The following is a description of a gene set: Human Gene Set: GOBP_REGULATION_OF_MOLECULAR_FUNCTION Any process that modulates the frequency, rate or extent of a molecular function, an elemental biological activity occurring at the molecular level, such as catalysis or binding. studied in species Homo sapiens, and this is the list of marker genes: KCNE3, TSG101, GAPDH, VMA21, ETAA1, ERBIN, NT5DC2, PSAP, TMSB4X, RASGRP2, SNCA, TERT, GABARAPL2, PSME3IP1, BAG5 (BAG cochaperone 5), WNT5A, VMP1, CBARP, GOPC, STX4, MAP3K11, HEY2, DTX3L, BCAS3, HTT, MT3, WNK2, TLR9, IL20, OPRM1, NOD2, ZNF16, USP33, ARHGAP11A, RHEBL1, CALM3, TLR4, SUMO4, ZFP91, ATP13A2, GNAS, KIT, PHB2, SYNGR3, DFFA, VAV3, MIR138-1, RALB, PIK3R5, FXN, LRRC52, BMP2, PDGFRB, SIRT1 (sirtuin 1), SOCS4, TESC, FGR, BTRC, RPS6KA4, KLRC4-KLRK1, EDNRA, EDN1, NUPR1, WRN, CASS4, CRNN, SNF8, ANGPT1, HAND2, ITGB1BP1, RCC2, RWDD3, CHTF8, RAP1A, DBI, PIP5K1A, RAN, COPS5, SRC, POU4F2, MDFI, COX17 (NCBI Gene Id 10063), PLA2G5, CRHBP, TBC1D10B, RAB3GAP2, VAV1, A2ML1, UBE2C, RIPOR1, CCDC88A, TFDP1, DEFB114, ESR2, MRNIP, CREBZF, USP7 (NCBI Gene Id 7874), KCNAB1, KLRK1, RACK1, ADARB1, APC2 (NCBI Gene Id 10297), CARD11, DOCK11, TFAP4, TRIM8, PYHIN1, CD300A, ACP4, KIF14, RCN3, ODAM, LRRC14, ABCE1, SOX11, TRIB2, HERC5, BAMBI, TBC1D30, EVI5L, MMP9, CCNE2, CTSS, GTF2F1, ATP5IF1, ACTN4, DIPK2A, EIF2AK4, USP44, GPRC5B, FOXC1, CNIH3, STAC2, MITD1, CORO1C (coronin 1C), INS, TPX2, KCNE2, CAND1, DOCK9, TRPC6 (NCBI Gene Id 7225), CGA, UNC119, TLE5, ACR, RELA, OXA1L, CRTC2, AGAP2, SNX18, FLT3, ADAR, HCK, SERPINB13, BDNF, CDC20, LIMS1, TMED2, MMUT, SERPINB8, TGM2, CAMK1, STK38, PCNA, PPIF, BTK, NPR3, CCR2, RHOC, TRIM15, GIPR, CNIH2, FSHB, PARP9, MYL4, GMNN, SUMO3, IL10, CD40LG, RARA, RGN, CACNA1D, SCN1B, CACNG7, AGER (NCBI Gene Id 177), STRIT1, PTPN22, RSU1, TOR1AIP2 (torsin 1A interacting protein 2), NIBAN2, MAP4K2, TRIM38, SCRIB, CRIPTO, PPP1R12A, CCDC125, ARHGAP44, CEP43, CDKN1B, TRIM27, GNAI2, PTPRC, KCNE1, NHEJ1, DHX9, ADGRV1, CNRIP1, NGEF, ARFGEF1, RGS1, ILRUN, EEF1A2, TRAF2, CRACR2A, FEM1B, XRCC1, ADAM17, TRIB3, RB1, ARHGEF16 (NCBI Gene Id 27237), RGS10, UBE2N (ubiquitin conjugating enzyme E2 N), AGRN, ITGA6, FIRRM, SKP1, ADGRG3, NLRP2B, TNNT2, MED25, BAX, PATE4, CDK5RAP1, PRSS22, PRDX3 (peroxiredoxin 3), ADORA2B, GNAI3, DYNAP, TCAF2, FEM1A, GCH1, PRELID1 (PRELI domain containing 1), COMMD1, RAB3GAP1, MST1R, CRHR1, TPD52L1, CDC25C, UBXN1, MIR92B, ECT2, TBC1D15 (NCBI Gene Id 64786), NFKBIL1, CARD10, ADIPOQ, LARS1, RALBP1, PPARG, IL18RAP, GPLD1, SIRT2, CD4, TBC1D20, CDC14B (cell division cycle 14B), PRKCH (protein kinase C eta), USP6NL, MIR27B, IL26, ATF2, RGS14, PLXNB2, CDK5R1, EPHB3, MET, CHP1, RAPGEF6, TNFSF18, NLRC5, GBA3, PLSCR1, SHISA7, SERPINB3, JUN, CHI3L1, TSSK4, MAPK14, SNX9 (NCBI Gene Id 51429), SYT14P1, TRIM5, LEP, SYDE2 (NCBI Gene Id 84144), TRAF6, C3orf33, BVES, SNX13, FGFR4, FGFR1, IL18R1, EPHA2, EGF, FGF2, CENPE, RAP2C, MID1IP1, NR0B2, APBA3, RABGAP1, TBC1D7, TERF2IP, GFI1, PSENEN, CARD18, ARHGEF2, SERTAD1, PNLIP, GNAT1, SERPINB4, TRIM21, PYDC2, BCL10, VAMP2, TNNI3, NTRK1, LAT, ABI1, LATS1, MAPK8, RGS6, SELENON, AHNAK, FBN1, BCCIP, NHERF1, MIDN, DPH3, VCP, TRAF3, FGD2, ITGA4, NEUROD1, NFKBIA, ZC3H15 (zinc finger CCCH-type containing 15), MID2, CACNG8, SFN, SLPI, TNF, PAM16, RAPGEF3, RAPGEF2 (Rap guanine nucleotide exchange factor 2), EIF2AK2, HAP1, ARHGAP42, DDIT3, EIF3C (NCBI Gene Id 8663), AKAP5, MAD2L2 (mitotic arrest deficient 2 like 2), OTULIN, PKMYT1, DAPK1, PRKN, CFHR5, DUSP1, FOXP3, CACNA1F, LCP2, NEUROG2, ELANE, FANK1, GAL, TRIM40, TMBIM1, IL19, RAB7B, ATPSCKMT, MYCNOS, TOR1AIP1, HMGB1, RBL1, AGT, BRMS1, CPNE1, ASPH, ID1, CCNT2, SNRNP70, STK11, NLRC4, PRLR, RALGAPA2, BMI1, PLXNB1, ADCY1 (adenylate cyclase 1), DOCK10, RFC2, MBP, NDFIP2, NCOA3, TRIM14, TNNT3, CCNY, ESR1, IL18, DDR2, SYK, EFHB, CAV3, DVL3, RIPK4, MAP2K1, ATP2A1, CLSPN, TRIM13, GNL3L, TXN, MST1, LEF1, FGF16, CFHR2 (NCBI Gene Id 82725), LMO4, HEG1, SSBP1, AIDA, STRADB, RNF220, MAP3K10, SPOCK3, RECK, EREG, FGFR2, IFI16, VSIR, AIM2, PABPN1, MAP3K5, WAPL (NCBI Gene Id 23063), S100A10, CACNA1C, ACOD1, CDK12, CAMK2D, LTF, ZNF593, UBQLN1, SETD6, ANKLE2, SPHK1, GZMA, HPF1, TRAF5, CACNG5, GUCA1A, CLOCK, TENM1, SNX6, EPHA4, DNAJC9, NEIL1 (NCBI Gene Id 79661), TARBP2, SPDYA, PINX1, RPL5, DRD5, TIGAR, GEMIN2, PIK3R6, GTF2H1, RASA4, BLM, SKI, MAP2K2, TBC1D2, DOCK8, FGF23, PRKCD, COMMD6, PRTN3, TCF3, CLN5, UFL1 (NCBI Gene Id 23376), CEP85, OAS3, TP53, RAP2B, CCNG1, TRIM22, GAS8, EDF1, FGD6, SGK2, MAP2K3, PARP10, BRSK2 (NCBI Gene Id 9024), GPRC5A, FOXA1, XRCC4 (X-ray repair cross complementing 4), TRIM52, GRM2, ARRDC4, ECSIT, ALS2, PLN, CACNB4, GABBR2, ANXA3, CDC25A (NCBI Gene Id 993), RSF1, CDK5RAP3, ZFP36, ZFYVE28, DAZAP2, CEMIP, HJURP, NPRL2, MEN1, WWP2, PLAUR, TSPYL2, ZBTB7A, EIF3E, TMC8, IL1B, PSMD10, SGK3, MAGEA2B, TNKS, GPR137B, LYN, HSPA1B, CRTC1, HEYL, SEMA4D (NCBI Gene Id 349236), MYL3, ARHGEF5 (Rho guanine nucleotide exchange factor 5), GREM2, TNFSF15, VAV2, PLIN5, FGF13, HAVCR2, TRIM37, CRB2, F2RL1, DNAJB2, TRAF4, STRADA, STYX (serine/threonine/tyrosine interacting protein), TSC1, ARRDC3, IFIT1 (NCBI Gene Id 8374), UBE2S, PRKCI, KDM4D, IFNG, STAC, SYNPO2, GADD45A, MTMR9, PDCD10, GALR1, PIBF1, CSNK1E, ROCK1, RANGAP1, CDKN2A, MYD88, NPPA, SGSM3, PDE3A, NEK10, MTPN, NOD1, NDFIP1, RFC4, PTK6 (protein tyrosine kinase 6), TNFRSF10B, FGF1, ERC1, MAP3K4, PPP1R3F, PDCD4, EFNA5, NLRP3, PAK2, TRIB1, PILRB, NCBP1, TLR6, AKT1, RALGAPB, RFK, PTK2, GATA3, LTB4R2, NF1, SLURP2, PBX1 (PBX homeobox 1), BTAF1, LDLRAP1, NOSIP (NCBI Gene Id 51070), CHUK, SASH1, FER, PSCA, MAP3K7, GALR2, SMG8, H1-0, ADCYAP1, SEMG1 (NCBI Gene Id 6406), OSR1, CEACAM1, EZH2 (NCBI Gene Id 392834), FOXS1, PLXNB3, SIPA1L1, WARS1, MAD2L1, RPL23, PHACTR4, RIC1, BMP4, CIMAP3, DNAJC24, TIMP1, CDKN1A, DNAJA1, TMIGD3, NFIB, ADD2, PROM2, RHOA, GSK3A, ERN1, MINK1, TIMP2 (TIMP metallopeptidase inhibitor 2), CMKLR1, ZGPAT, PRKCQ, ARHGEF7, KCNQ1, MAPK8IP1, BTBD1, DSCC1, RAB11FIP2, CSF1R, IKBKG, ARAP1, NTRK2, VPS25, KCNRG, RHOG, RIPK1, STING1, EPPIN, NOTCH1, MIA2, STIM2, NSD1, E2F1, JMJD8, PFN2, TOM1L1, CFHR1, CACNG3, USP17L2, TRIM34, CAMK2A, CRH, C8orf44-SGK3 (C8orf44-SGK3 readthrough), CHTF18, FGD5, GRM3, RASIP1, IFIT2, GATA1, FICD, XIRP1 (NCBI Gene Id 191580), ARHGAP11B, SZT2 (SZT2 subunit of KICSTOR complex), DUSP7, CAPN1, CACTIN, STMN1 (stathmin 1), MACROH2A1 (NCBI Gene Id 9555), JTB, AVPR2, HES1, IL24 (NCBI Gene Id 11009), AHSA1, NIPSNAP2, CACUL1, PTPRJ, LRRK2, SIK1, FLNA, CDC37, RGS16, EVI5, PIAS2, POU4F1, CARD14, CDKN1C, SGK1, SRF, SERPINB1, CACNG2, TFDP3, MAGEA2, TANK, RIPOR2, THY1, DEPTOR, KDM5A, PRKD2, TLR3, BCR, LDB1, RPS2, HPCA, ENPP1 (ectonucleotide pyrophosphatase/phosphodiesterase 1), MTSS2, NWD1, TRIM6, CYP1B1, FGF10, DDX11, IGF1, GCKR, HSPA1A, RPS6KA5 (NCBI Gene Id 9252), INCA1, MTDH, NRG1, C14orf39, EIF4G1, PEX14, CARD9, RNF25, NEUROG1, MAP3K13, NLRC3, CARD16, RGS8, MMD, ERBB2, PXK, CALM2, KSR1, ABR, STIM1, AZIN2, GLA, CDKN3, AHCYL1, CSNK2B, FGF12, ZIC2, VCPKMT, PSEN1, PPIA, ALK, IRAK1, ITGB1, RPL11, MVP, TCAF1, RDX, TLR2, TAFA4, XRCC6, RBL2, CHP2, ARID5B, FGF18, TAF7, ADORA3, LRRC55, RTRAF, ARRB1, TWIST1, AURKA, GAS6, SYAP1 (NCBI Gene Id 94056), RLN2, PRDX5, HMGA2 (NCBI Gene Id 8091), FZR1, CAMKK2, MAGEC2, CDH3, PYDC1, PIK3CG, RPS3, SYMPK, ROR1, JAK2, RNF2, NEUROD2, APC, STIMATE, EIF4A2, RAPGEF1, CDT1, IKBKB, RALGAPA1, AKT1S1, RRP1B, ADAP1, YWHAG, TRIM26, SVBP, PKIA, ABL1, MAPK3, RIPK3, CAP1, APOE, GNB5, CCNK, MTURN, PRMT2, CEBPG, STK36, TRIM31, GOLGA2 (golgin A2), ORAI1, HIPK3, RAMP3, CAP2, HLA-DRB1, PUM3, PLK1, PIM1, SYDE1, MARCHF6-DT, SPOCK2, AKTIP, CACNG4, SRCIN1, EMP2, S100A9, CD74, PYCARD, URI1, DIRAS1, IRGM, LRPAP1, PTPRF, TAB2, TPM2, PPM1E, GRN, TCEAL7, TRIM62, COMMD7, PDGFB, MMD2, SOD1, TRAF1, CR1, CLU, B3GAT3, FLOT1, SH3BP1, ZNF431, ANK3, CAB39, ADAM15, RASGRP1, EPB41, DACT1, LYNX1, CACNB3, ERRFI1, GPSM1, GRP, NES, DIRAS3, NMD3, PTPN1, CHMP6, EP300, CTNNBIP1, WNK3, SOCS5, ASAP3, PRKD1 (protein kinase D1), SPINDOC, NDEL1, ADD1, PRKCZ, PFN1, ID2, SRGAP2, ADCY8, FLT1, GSK3B, DRD4, LILRA5, STOX1, SPHK2 (sphingosine kinase 2), ID3, GSKIP, BCL3, EDNRB, DOK7, USP9X, SEMG2, NVL, TIAM1 (NCBI Gene Id 7074), FGD1, PKHD1 (NCBI Gene Id 5314), EPHA3, RTN4R, FGD4, PEX19 (peroxisomal biogenesis factor 19), CREB3, PRKG1, RGP1, PAQR3, CCAR2, FBXO5, DSTYK, SERPINB9, PLAAT4, PPP1R17, CLEC12B, RGS7, STK39, POLG2, JPH2, P2RY11, CALCA, SERPINA5, PIH1D1, LATS2, FGD3, TAFA1, DOT1L, CDK5R2, RBCK1, LGALS9, IDE, TAOK3, BANF1, LRRC26, LRRC38, RFC5, GPR35, XRCC5 (NCBI Gene Id 7520), SETMAR, BCAR3, CFTR (NCBI Gene Id 1080), SLN, HNRNPU, CDC6, FMR1, RPS7, CASQ1, ECM1, NEDD9, CRK, NME1, TRIM32, DIRAS2, OAS1, GLP1R, RFC3, COPS8, MIR148A, SIRT4, RNF31, ACTN2, ZNF622, RTKN2, CALM1, CYLD, UVRAG, HGS, PRRT1, TRIM25, ZC4H2, S100A8, RAP1GAP, SUMO1, EPM2A, UBLCP1, GTF2B, CIB1, RD3, GUCA1ANB-GUCA1A, TNFRSF10A (NCBI Gene Id 8797), CAMK1D, DHX33, NPM1, FGFR3, LDB2, SH3BP4, SIRT3 (NCBI Gene Id 23410), S100A12, STAC3, ARL2, SGSM2, SMO, DDRGK1, PIN1, DBNDD2, LRCH1, CCNT1, DAB2IP, CHTOP, DNAJB11, EDN2, FETUB (fetuin B), TCIM, EPHA5, CTTNBP2NL, NET1 (NCBI Gene Id 10276), RASSF2, PTK2B, PAXIP1, ARRB2